Given this list of marker genes Gjc2, Adcyap1, Lyn, Trf, Afdn, Nog, Lrp2, Shh, Sirt2, Mios, Ptprz1, Cdh2, Emx1, here is a description of the gene set: species: Mus musculus The multiplication or reproduction of oligodendrocyte progenitor cells by cell division, resulting in the expansion of their population. Oligodendrocyte progenitors give rise to oligodendrocytes, which form the insulating myelin sheath of axons in the central nervous system. Mouse Gene Set: GOBP_OLIGODENDROCYTE_PROGENITOR_PROLIFERATION